The following is a description of a gene set: species: Homo sapiens Enables the transfer of copper (Cu) ions from one side of a membrane to the other. Human Gene Set: GOMF_COPPER_ION_TRANSMEMBRANE_TRANSPORTER_ACTIVITY, and this is the list of marker genes: ATP7A, SLC46A3, SLC11A2, ATP7B, SLC31A1 (solute carrier family 31 member 1), SLC31A2, SLC39A11